Given this list of marker genes Fgf16, Fgf18, Irs2, Fgf17, Atp6v0a4, Shc1, Ptpn11, Atp6v1c1, Fgf9, Fgf1, Atp6v1f, Fgf4, Ctsd, Atp6v1g2, Mapk3, Grb2, Gab1, Fgf6, Fgf5, Pik3ca, Atp6v0a2, Atp6v0d1, Atp6v0e, Atp6v0c (ATPase, H+ transporting, lysosomal V0 subunit C), Insr, Fgf8 (fibroblast growth factor 8), Atp6v0b, Sos1, Atp6v0e2, Fgf2, Ptprf, Klb, Pik3r2, Fgf20, Pik3cb, Fgf23, Atp6v0a1, Atp6v1g3, Atp6ap1, Fgf3, Them4, Trib3, Ide, Fgfr1, Atp6v1e2, Fgf10, Atp6v1g1, Grb10, Atp6v1b2, Fgf15, Atp6v0d2, Pdpk1, Flt3l, Pik3r1, Atp6v1c2, Atp6v1d, Fgfr4, Pik3c3, Tlr9, Frs2, Akt2, Fgf22, Pik3r4, Ins1, Atp6v1b1, Atp6v1h, Atp6v1e1, Atp6v1a, Ptpn1, Tcirg1, Fgfr3, Fgf7, Kl, Mapk1, here is a description of the gene set: studied in species Mus musculus Mouse Gene Set: REACTOME_SIGNALING_BY_INSULIN_RECEPTOR Signaling by Insulin receptor